The following is a description of a gene set: species: Mus musculus from publication Chen Y, Wang X (PMID 31504780) Mouse Gene Set: MIR_202_3P Genes predicted to be targets of miRBase v22 microRNA mmu_miR_202_3p in miRDB v6.0 with MirTarget v4 prediction scores > 80 (high confidence targets)., and this is the list of marker genes: Ston2, Stab2, Ikzf2, Adamts20, Trpm6, Zfyve26, Slc9a9, Arhgap12, Tet3, Skil, Ypel2, Rcn1, Cnot6l, Nrk, Ccnd1, Zwint, Ercc6, Cyth3, Cd276 (NCBI Gene Id 266672), Rock1, Ccnh, Adamts15, Stx3 (NCBI Gene Id 20908), Thoc2, Rnf139, Zfp455, Arid3a, Ccnd2, Bend4, Mnt, Cebpd, Tab2, Il6, Serinc4, Rab8b, Acvr1c, Cacna1e, Stxbp5, Pxdn, Col27a1, Plekho1, Adamts8, Adrb3, Fndc3a, Adcy9, Prpf38b, Wdfy3, Dst, Dnajb9, Col4a2, Ctdspl2 (NCBI Gene Id 51895), Fbxl12, Zfp644, Trim71, Mycs, Rbfox2, Bcl7a, Map4k3, Ghr (growth hormone receptor), Dlc1, 9930012K11Rik, Senp2, Bsn, Galnt2, Tmem260, Gpcpd1, Nr6a1, Pcgf3 (NCBI Gene Id 69587), Hmgcs1, Semp2l2a, Rb1, Rslcan18 (regulator of sex-limitation candidate 18), Galnt12, Capn6, Dpysl3, Msi2, Leprotl1, Hdgfl3, Cert1, Nipal4, Ndst3, Strbp, Stil, Crem (NCBI Gene Id 12916), Arid3b, Ppargc1b, Pbx3, Fam135a, Arl5a, Slc30a4, Lama1, Celf5, Utrn, Dnajc1, Lrig2, Semp2l1, Nid2, Tbkbp1, Cd200r1, Fbxo30 (F-box protein 30), Semp2l2b, Cap1, Tstd3, Loxl4, Hectd2, Il10, Tmem65, Pik3ip1, Pogz, Pou2f1, Zdhhc25, Galnt1, Agap1 (ArfGAP with GTPase domain, ankyrin repeat and PH domain 1), Limd1, Slco5a1, Slc7a14 (solute carrier family 7 (cationic amino acid transporter, y+ system), member 14), Gtpbp2, Gramd1c, Rorc, Dzip1, Kdm3a, Rbfox1, Hsd3b2, Mttp, Gabra6, Pappa, Tspan5, Mef2c, Lpgat1, Nap1l1, Cpeb2, Mtmr12, Trhde, Ecm2, Mmd, Nectin3, Kif2a, Trib1, Tecpr2, Gabpa, Epha3, Acvr2a, Gng2, Fignl2, Col15a1, Mest, Stard13, Exoc5, Eya3, Gramd2b, Syt2, Xkr4, Cpeb3, Zc3h11a, Ints2, Vstm5, Has2, Zswim4 (NCBI Gene Id 212168), Fasl, Shank2, Fgd4, Ppargc1a, Ago4, Nipal1, Tmc7, Dtx4, Hk2, Pygo2, Scyl3, Rab11fip2, Pald1, Lbh, Atg16l1, Adipor2, Slc25a53, Crtap, Mex3a, Onecut3, Nsd3, Snx5, Mycn, Adamts14, Mapk6, Dusp1, Entrep2, Gdpd1, Dtx2, Mob4, Peg10, Adamts12, Onecut2, Sh3rf3, Igf2bp3, Tmprss2, Slc38a9, Akain1, Adrb2, Nfxl1 (NCBI Gene Id 76396), Ark2c, Zfp516, Pkn2, Fign, Stard3nl (NCBI Gene Id 76205), Ehhadh, Btg2, Col4a1 (NCBI Gene Id 207132), Cdc34, Hecw1, Cpeb4